The following is a description of a gene set: Human Gene Set: GOBP_DENSE_CORE_GRANULE_TRANSPORT studied in species Homo sapiens The directed movement a dense core granule within a cell., and this is the list of marker genes: TRIM46, KIF5B, MAP2, SYT4, SYBU, KIF1C, KIF5A, KIF1A, PPFIA2, KIF1B, TANC2